Given this list of marker genes Phc1, Samd11, Phc3, Cbx2, Bmi1, Pcgf3, Cbx6, Samd7, Phc2, Ring1, Pcgf1, Cbx4, Cbx8, Rnf2, Cbx7, Pcgf6, Pcgf2, Pcgf5, here is a description of the gene set: Mouse Gene Set: GOCC_PRC1_COMPLEX A multiprotein complex that mediates monoubiquitination of lysine residues of histone H2A (lysine-118 in Drosophila or lysine-119 in mammals). The complex is required for stable long-term maintenance of transcriptionally repressed states and is involved in chromatin remodeling. species: Mus musculus